Given this list of marker genes MIDEAS, MTMR3, PSTPIP2, CFAP58, TBC1D15, ZNF546, NCBP2, ZNF280D, CEP120, TRIM66, ZNF34 (zinc finger protein 34), TFF2, RBFOX2, FUT9, MRPL11, NADSYN1, CAPN5, DAO, ARID4B, KMT5B, TGFA, HNRNPH2, ARHGEF18, GXYLT1, HFE, DNAJC14, HYKK, CACNA2D1, PLA1A, URI1, RPS6KB1, ADAR, ERCC6L2, GRIN2A, ZNF99, FUNDC2, SCP2, EP300, RUNX1T1, EXOC6B, FABP7, ZDHHC6, SLC16A7, SMARCD2, ARHGEF9, KSR2, DRP2, TOP1, COQ7, NSD1, ZNF3, CD200R1, EGR3 (early growth response 3), EXOC8, POLR3E, CD5L, ENSA, CDCA7, NMD3, C9orf72, YBX3, PHF19, ADA2, NEK3, SLC29A2, LMNB1, DNAJC5G (DnaJ heat shock protein family (Hsp40) member C5 gamma), FBXL7, TNS4 (NCBI Gene Id 84951), SH3BP4, PMP2, AMMECR1L, SLC6A16, NECTIN1, DERL2, KAT2B, FGF2, TTC39B, LIX1, IPO5, SH3TC2, RBMS3, AGFG1, RNPC3, COX8C, HVCN1, ERCC8, SMARCC1, MS4A7, H2BW2, MTCH2 (mitochondrial carrier 2), TTC3, ZDHHC9, SLC38A8, VPS50, SV2A, KRT24, ZNF250, PHLDA1, ATRX, PTPN11, SPTBN1, PDIK1L, GTF3C1, EYA4, MMP10, ZCCHC3, AADAT, ZNF652, INSR, TTC13, EPM2A, SH3GLB1, C12orf71, KDM4C, AVPR1A, FIGN, KRT76, AMIGO2, ADAMTS18, SYT14, B3GALT2, SCAND3, ZBTB10, TTC8, MEIS2, C2CD2, ZBTB43, MBL2, NPHS2, HNRNPC, IL1RAP, GABRA4, HOXB3, DDN, ZNF609, TANC2, CLDN1, F9, JAG2, MYO1D, TRIM22, FECH, MYSM1, SPRY1, GALNT15 (NCBI Gene Id 117248), ZNF257 (zinc finger protein 257), CFLAR, CRELD1, GNA12, MYB, DGKK, KLK7, BEND4, HINT3, MED11, PLOD2, GIN1, CCER1, RIMKLA, MUL1, IPO11, FAM217B, MRC1, SKIL, CNTLN, ADGRL2, PRIM2 (DNA primase subunit 2, NCBI Gene Id 5558), IRF6, CEP85, HAS3, SLC7A11, DCTN4, NID1, TAC3, LIN7A, BTG1, LAMP2, BCAT1, KRTAP4-9, NME6, VPS13A, DNAJB14, WEE2, STS, NAA25, FKBP5, HLA-DQA2, AZI2, PABIR3, NUFIP2, NSD2, GRIA3, NOS2, SRRM4, RTL5, TMEM184C, SLC25A22, CTSG, KCNK2, XPO1, LACTB2, SLC1A6, WFIKKN2, GPR146, LANCL3, ZNF626, PASK, CIMIP6, DLG1, G6PC3, AFF3, PLEK, ABHD3, CNTN4, NRXN2, DNAJC18, PHACTR2, CCDC8, here is a description of the gene set: Human Gene Set: MIR3915 Genes predicted to be targets of miRBase v22 microRNA hsa-miR-3915 in miRDB v6.0 with MirTarget v4 prediction scores > 80 (high confidence targets). from publication Chen Y, Wang X (PMID 31504780) species: Homo sapiens